Given this list of marker genes RCHY1, MNT (MAX network transcriptional repressor), IFI27L2 (NCBI Gene Id 83982), NDUFB5, GYG1, DUSP6, SFI1, HDAC7, MAF1, RECQL5, MPC2, RABGEF1, MIA3 (NCBI Gene Id 440718), PRDM1, SELENOM, PSRC1 (proline and serine rich coiled-coil 1), CCN6, DNAJC3, ST6GALNAC6, NDST2, SPO11 (SPO11 initiator of meiotic double strand breaks), RABGAP1L, GLA, CREB3, DBP, RNF103, DAP, ARFGEF2, GNPTAB, VCL, KIAA0040, CCDC107, IQGAP2, N4BP2, TGFBR3, MSI2, MMGT1, SLC12A6, SYS1, REEP4, DOCK11, USP38, SNTB2, HIVEP3, PROS1, TACC2, ZNF710, GSTT2, MACO1, ELOVL6, B3GNT2 (NCBI Gene Id 55878), PTCH1, IFITM2, SLC31A1, IRAG2, CCL4 (NCBI Gene Id 6351), RHOQ, ACAA1, TMCO1, GPX4, ZNF280B, ARMCX3, ITFG1, NFRKB, FAM3C, SIL1, TMEM205, TMEM50A, AGO4, HNRNPH3, NEMP1, FOXM1, SNRK, TMEM106B, SDC1, PAIP2 (poly(A) binding protein interacting protein 2), ZMYM5 (NCBI Gene Id 9205), PER1, UGCG, SEMA4B, RASA4, TMEM165, CMTM7, PRDX2, AP3S1, CD200, MT2A, ANXA2 (annexin A2), PML, TMC6, LRP10, DDB2, ZFTRAF1, PANX1, FAM78A, NSD3, ERLIN1, LSR, SMPD1, CSNK1E, RBL2, CD36, GNAQ, AHR, TP53BP2, TSPAN13, KLHL6, TXNDC16, TANC2, MBD4, SPP1, IPMK, SLC44A1, TRIB1, MRPL34, RASSF3, DCAF6 (NCBI Gene Id 55827), DCTN2, TAX1BP1, PLXNB2, ERO1B, UBALD2, PRPF18, ITM2A, PIP4K2C, TM4SF5, FGD3, LPAR2, TCEAL9, EVA1B, GIT2, STAT4, NSA2, L3MBTL3, CTSH, RPLP0, ARFGAP3, NAPRT, INPP5K (NCBI Gene Id 51763), SLC9A5, METRNL, SLC37A4, ZNF394, TOB1, COPS3, MED12, MT1E, RBM5, UROD, PNRC1, LAX1, RRAGD, CSAD, LMTK2, ARHGEF39, ETV5 (NCBI Gene Id 2119), TRAPPC6A, TNFRSF13B, NDUFB11, VPS13A, ESYT2, UBE2B, FAM3A, JPT1, SLC66A2, ACYP1, CDC42BPG, HPGDS, GPR155, CNPY2, LEPROTL1, TMED10, IDH2, DGCR6, KDM5A, BTG2, TLK1, SIDT2, ATG13, RASD1, PRDX4, ECI2, RASIP1, CD38 (NCBI Gene Id 952), CRYBG3, POU2AF1, SAPCD2, RBM47, ARID4A, PSEN1, FOXO3, ATP5MG, UBE2H, FLCN, CNST, YIPF4, PPT1, XRCC1, FBXW7, ZSWIM8, here is a description of the gene set: During acute viral infections, naïve CD8+ T cells differentiate into effector CD8+ T cells and, after viral control, into memory CD8+ T cells. Memory CD8+ T cells are highly functional, proliferate rapidly upon reinfection and persist long-term without antigen. In contrast, during chronic infections, CD8+ T cells become “exhausted” and have poor effector function, express multiple inhibitory receptors, possess low proliferative capacity, and cannot persist without antigen. To compare the development of functional memory T cells with poorly functional exhausted T cells, we generated longitudinal transcriptional profiles for each. from publication Doering TA, Crawford A, Angelosanto JM, Paley MA, Ziegler CG, Wherry EJ (PMID 23159438) species: Homo sapiens Human Gene Set: GSE41867_LCMV_ARMSTRONG_VS_CLONE13_DAY8_EFFECTOR_CD8_TCELL_UP Genes up-regulated in CD8 T effector cells at day 8 of chronic infection: LCMV-Armstrong versus LCMV-Clone 13.